Given this list of marker genes PLTP (NCBI Gene Id 5360), ESYT1, GABARAPL3, GABARAPL2, ESYT2, CD300A, ESYT3, TREM2, NF1, MAP1LC3A, MAP1LC3B2, GABARAPL1, MAP1LC3C, MAP1LC3B (microtubule associated protein 1 light chain 3 beta), ANXA11, PEBP1, GABARAP, here is a description of the gene set: Human Gene Set: GOMF_PHOSPHATIDYLETHANOLAMINE_BINDING species: Homo sapiens Binding to a phosphatidylethanolamine, a class of glycerophospholipids in which a phosphatidyl group is esterified to the hydroxyl group of ethanolamine.